Given this list of marker genes ANG, ELF3, SCNN1B, ASPH, AKAP12, RRAGD, SAT1, LOXL2, SPOCK1, GLRX, DST, STC1, SAMD4A, PIM1, S100A2, TXNIP (thioredoxin interacting protein), PLAUR, SRD5A3, GBE1, DTNA, PLAC8, S100A6, P4HA1, VEGFC, ERO1A, CAV1, CSRP2 (NCBI Gene Id 7882), TNFAIP8 (NCBI Gene Id 25816), INSIG2, SERPINE1, DSC2, ITPR1, EGLN3, FAM162A, PFKFB3 (NCBI Gene Id 5209), DDIT4, TMEFF1 (transmembrane protein with EGF like and two follistatin like domains 1), ATG14, ADM, PGM1, TMEM45A, OPN3, TBC1D3F, TGFBI, GJA1, NDRG1, CADM1, ENO2, GPRC5A, CITED2, HK2, ISG20, GYS1, STC2, CSGALNACT1, P4HA2, ATXN1, DPYSL4, LOX, INHA, CXCR4, RBCK1, AHNAK2, PGK1, HILPDA, NR3C1, PDK1, HLA-DRB1, IGFBP5, GPR87 (NCBI Gene Id 53836), LIMCH1, DAAM1, PAM, CA9, CYB5A, YEATS2, ADORA2B, S100A4, SOX9, YPEL1, QSOX1, MXI1, RLF, RNASE4, OLFML2A, PRKCA, VLDLR, CEMIP, EGFR, MGAT5, STBD1, ANGPTL4, MAFF, SRPX, KDM3A, MET, OBSL1, SLC2A1, ARTN, VEGFA, PPFIA4, SFXN3, HEY1, EGR1, ILVBL, NAP1L1, ZNF395, FAM13A, CD59, PFKP, ALDOC, NFIL3, IGFBP3, BNIP3L, WSB1, GDF15, CCNG2, BHLHE40, FOS, EGLN1, BNIP3, SPAG4, ATF3, JUN, SLCO4A1, SPRY1, KLHL24, CCN5, AK4, KLF6, ZNF292, KLF7, FYN, here is a description of the gene set: from publication Elvidge GP, Glenny L, Appelhoff RJ, Ratcliffe PJ, Ragoussis J, Gleadle JM (PMID 16565084) Genes up-regulated in MCF7 cells (breast cancer) treated with hypoxia mimetic DMOG. species: Homo sapiens Human Gene Set: ELVIDGE_HYPOXIA_BY_DMOG_UP Studies of gene regulation by oxygen have revealed novel signal pathways that regulate the hypoxia-inducible factor (HIF) transcriptional system through post-translational hydroxylation of specific prolyl and asparaginyl residues in HIF-alpha subunits. These oxygen-sensitive modifications are catalyzed by members of the 2-oxoglutarate (2-OG) dioxygenase family (PHD1, PHD2, PHD3, and FIH-1), raising an important question regarding the extent of involvement of these and other enzymes of the same family in directing the global changes in gene expression that are induced by hypoxia. To address this, we compared patterns of gene expression induced by hypoxia and by a nonspecific 2-OG-dependent dioxygenase inhibitor, dimethyloxalylglycine (DMOG), among a set of 22,000 transcripts, by microarray analysis of MCF7 cells. By using short interfering RNA-based suppression of HIF-alpha subunits, we also compared responses that were dependent on, or independent of, the HIF system. Results revealed striking concordance between patterns of gene expression induced by hypoxia and by DMOG, indicating the central involvement of 2-OG-dependent dioxygenases in oxygen-regulated gene expression. Many of these responses were suppressed by short interfering RNAs directed against HIF-1alpha and HIF-2alpha, with HIF-1alpha suppression manifesting substantially greater effects than HIF-2alpha suppression, supporting the importance of HIF pathways. Nevertheless, the definition of genes regulated by both hypoxia and DMOG, but not HIF, distinguished other pathways most likely involving the action of 2-OG-dependent dioxygenases on non-HIF substrates.